Given this list of marker genes NOSIP, NPR3, INS, GLA (NCBI Gene Id 2717), ESR1, IL1B, LEP, GCH1, here is a description of the gene set: studied in species Homo sapiens Human Gene Set: GOBP_REGULATION_OF_NITRIC_OXIDE_SYNTHASE_ACTIVITY Any process that modulates the activity of the enzyme nitric-oxide synthase.